The following is a description of a gene set: studied in species Homo sapiens from publication Chen Y, Wang X (PMID 31504780) Genes predicted to be targets of miRBase v22 microRNA hsa-miR-7159-5p in miRDB v6.0 with MirTarget v4 prediction scores > 80 (high confidence targets). Human Gene Set: MIR7159_5P, and this is the list of marker genes: ZNF718, TNKS2, CRACR2A, HOOK3, CAV1, DDX52, BLOC1S6, ARL4A, SEMA6D, CDSN, RABGAP1L, USP8, CELF3, PUM2, CADM2, GABPB1, ESCO2, SORCS3 (NCBI Gene Id 22986), NRG3, ESM1, E2F5, GCFC2, OXR1, DCAF5 (NCBI Gene Id 8816), SPIN4, JADE1, PTGR2, VPS35, SMAD2, KRTAP24-1, CHST9, PCDHA8 (protocadherin alpha 8), EPB41L5, DCUN1D1, PLPP5, DOK6, ZNF782, NUDCD1, SRSF7, PSD3, FECH, ACACA, ST7, PXT1, PABIR1, GSE1, TLE1, C5orf22, ARGLU1, RNF170, OTUD4, SH2D4B, MCTS1, FRMD3, CPLX1, THUMPD3, GALNT3, ARMC8 (armadillo repeat containing 8), MEIOC, SPATA22, SLC10A7, TMCO1, SOX14, RND3, LAMP2, SFXN2, ZNF501, UBL3, CISD1, CLDN10, DUSP18 (dual specificity phosphatase 18), GDAP2, TENT4B, TRIM47, TASOR, LUZP4, GUCY1B1, ACOT9, STIM2, PPIE, ZKSCAN8, HOXA4, SYT15, RGS20, TRPC3, SLC46A3, MAP3K2, DAZ2, MRGPRX2, ZNF92, KDM3B, RCOR3, LRP11, RBM7, MMGT1, PAX6 (paired box 6), GET1, TMEM245, ETV5, LIFR (NCBI Gene Id 3977), NSUN4, PRTG, PCDHA7, NUCKS1, TBC1D30, PHTF2, BCLAF3, CALCR, ETS1 (ETS proto-oncogene 1, transcription factor), C1orf115, LDHAL6B, MBD2, ADRA1A, HMGB1, TRIM58, SLC7A11, BRWD1, ARRDC3, DTNA, CLIC5, TXNDC15, DCAF8L1, HIPK2 (NCBI Gene Id 653052), PCDH9, DUSP23, AFDN, RFC3, SPAG11B, MEI1, NPAT, ZIC2, GTF2A1, BRD4, ZNF652, IGF1, TVP23C, KDM2B, ATAD2B, EPHA4, PCDHAC2, CLECL1P, TTC13, UBN2, CLTRN, ADIPOQ, PAX9, MYO3B, PCDHA9, RFX7, EXOC6, KIF3C, SOX7, MINAR1, SSH1, HASPIN, ZNF48, ZNF254 (NCBI Gene Id 9534), CLOCK, GCNT1, LRFN5, PAPOLA, TMEM207, C22orf39, MAGEA4, PCDHA1, LRATD2, ALDH3A2, SSX2IP, KCNJ3, CHFR (NCBI Gene Id 56732), CPEB2, AP1S2, HGF, NHLH2, MORF4L1, PGR, ZCCHC14, WAPL, PRPSAP1, CSTF2, TMEM65, GOLT1B, PPM1A, PRKAA2, FAM216B, PICALM, SH3GLB1, DCAF10, SSR1, HOPX, PCDHA11, PPP2R2C, KHDRBS3, CCER1, TMX3, PAPPA, NRCAM, PHC3, ARID4B, L2HGDH, SMIM8, LCA5, TAF4B, TUBB, FMN2, ELAPOR2, MIGA1, CAPRIN1, RNF8, QKI, IL2, SEMA3D, DAZ3, RCAN3, DAZ1, MORF4L2, NAA16, ABCA13, CEP170, BIRC2, REL (NCBI Gene Id 5966), MITF, PCDHA13, ETNK1, INTS2, ILF2, CUL4B, GPBP1L1, ISCA1, CEP85L, NAT2, ZNF326, ADAMTSL3, ZNF470, ZBTB11 (zinc finger and BTB domain containing 11), KLHL15, JMJD1C, PCDHA5, CLCN3, PCDHA3, FOXO3, C15orf40, FZD5, WAC (NCBI Gene Id 55468), MID1, SLC6A11, COL19A1, SP8, TFB2M, PAM, RAPGEF2, CYP20A1, SCOC, ZEB1, SELENOT, WDR44, DAZ4, CREBRF, LARP7, TVP23B, PTPN11, NMU, NUFIP2, CAT, ZNF639, SC5D, CRIM1, WTAP, HYCC2, TLR6, GJB7, CFAP126, CHRNB1, STRN3, SLC9A2, ZNF800, APC, REPS2, SLC25A36, CYREN (NCBI Gene Id 78996), NDUFAF7, AGTPBP1, ZFP28, ASH1L, GLCE, RFXAP, CPNE4, CASP2, RPGRIP1L, P3H4, MGME1, CYB5B, GAL3ST4, FOXP1, PYROXD1, MAP10, ZNF84, TOMM70, GNE, SAP18, PCDHA10, CREBZF, FAM83A, HDAC9, EIF1AX, PAFAH2, CAMK2D, GPRASP2, PGGT1B (protein geranylgeranyltransferase type I subunit beta), KPNA4 (karyopherin subunit alpha 4), RORA (RAR related orphan receptor A), SCGB2A2, ZBED4, RALGAPB, SGIP1, COL15A1, FOXC1, PCDHA6, HNRNPK, PIPOX, ERO1A, NAA25, DCK, ZNF709, ATOSA, MS4A6A, NPY5R, FNDC5, HNMT, DNAJC27, PCDHAC1, PBLD, MYSM1, ANKRD13C, SLC12A5, RNASE6, VPS37A, RNPS1, VGLL3, PRELID1, RFX3, AHNAK2, ARPP19, EEF1E1, RIC3 (RIC3 acetylcholine receptor chaperone), LRRC4, CEP83, SSR3, HNRNPUL2, FBXL22, PDE4D, GRIA4, HIVEP1, RASA1, ACSL3, AP1M1, PCDHA2 (NCBI Gene Id 56146), TMEM106B, PCDHA4, NAP1L1, KIAA0825, CCDC34, UBE2D3 (ubiquitin conjugating enzyme E2 D3), SCAF11, PCDHA12, UBE2W, NPHP4, RPS6KA6, RAB18, TM9SF1, ST3GAL1, ANKRA2